Given this list of marker genes AHI1, TTC8, CPLANE1, CC2D2A, FLNA, PCM1, KIAA0586, ZNF423, BBS9, TMEM17, TMEM237, NPHP3, PDE6B, ARMC9, RHEB, TCTN1, NEK8, TCTN2, CSPP1, PCNT, MTOR, TMEM67 (NCBI Gene Id 91147), TMEM231, CEP290, MRE11, BBS1, BBS5, PDE6A, INPP5E, NPHP1, CETN1, ARR3, MKS1, RP2, ARL2, BBS2, DVL3, MYO5A, RAD50, CETN2, CCP110, NPHP4, CEP97, RPGRIP1L (NCBI Gene Id 23322), PIBF1, MYO6, UNC119, PDE6D, DVL1, KAT5, ARL13B, SUFU, CEP164, TCTN3, PDE6G, ATF4, B9D2, ARL3, CEP104, PARP1, CEP120, INVS, TMEM216, B9D1, TMEM138 (transmembrane protein 138), BBS4, NIN, OFD1, BBS7, RHOA, ATM, RAB8A, RAB3IP, ANKS6, SHH, CEP41, here is a description of the gene set: Human Gene Set: WP_JOUBERT_SYNDROME species: Homo sapiens Joubert syndrome